The following is a description of a gene set: Mouse Gene Set: CUI_T_CELL_GD_TPO_RESPONSE_DN Cytokines mediate cell-cell communication in the immune system and represent important therapeutic targets. A myriad of studies have highlighted their central role in immune function, yet we lack a global view of the cellular responses of each immune cell type to each cytokine. To address this gap, the authors created the Immune Dictionary, a compendium of single-cell transcriptomic profiles of more than 17 immune cell types in response to each of 86 cytokines (>1,400 cytokine-cell type combinations) in mouse lymph nodes in vivo. A cytokine-centric view of the dictionary revealed that most cytokines induce highly cell-type-specific responses. For example, the inflammatory cytokine interleukin-1β induces distinct gene programmes in almost every cell type. A cell-type-centric view of the dictionary identified more than 66 cytokine-driven cellular polarization states across immune cell types, including previously uncharacterized states such as an interleukin-18-induced polyfunctional natural killer cell state. species: Mus musculus Genes negatively differentially expressed in cell type: γδ T cell upon treatment with cytokine: TPO in mouse lymph nodes in vivo. from publication Cui A, Huang T, Li S, Ma A, Pérez JL, Sander C, Keskin DB, Wu CJ, Fraenkel E, Hacohen N (PMID 38057668), and this is the list of marker genes: Klf6, Btg2, Stk17b, Uba52, Dusp1, Fos, Ppp1r15a, Nr4a1 (NCBI Gene Id 15370), Junb, Cxcr4